Given this list of marker genes FOXJ1, CBLB, IRAK3, NR5A2, LILRB2, ITCH, HLA-G, TGFBR2, CD3E, LILRB4, FOXP3, IDO1, here is a description of the gene set: Any process that activates or increases the frequency, rate, or extent of tolerance induction. Human Gene Set: GOBP_POSITIVE_REGULATION_OF_TOLERANCE_INDUCTION studied in species Homo sapiens